The following is a description of a gene set: Genes up-regulated in gastric cancer cell lines resistant to 5-fluorouracil. studied in species Homo sapiens Human Gene Set: KANG_FLUOROURACIL_RESISTANCE_UP from publication Kang HC, Kim IJ, Park JH, Shin Y, Ku JL, Jung MS, Yoo BC, Kim HK, Park JG (PMID 14734480) PURPOSE: A major obstacle in chemotherapy is treatment failure due to anticancer drug resistance. The emergence of acquired resistance results from host factors and genetic or epigenetic changes in the cancer cells. The purpose of this study was to identify differentially expressed genes associated with acquisition of resistance in human gastric cancer cells. EXPERIMENTAL DESIGN: We performed global gene expression analysis in the acquired drug-resistant gastric cancer cell lines to the commonly used drugs 5-fluorouracil, doxorubicin, and cisplatin using Affymetrix HG-U133A microarray. The gene expression patterns of 10 chemoresistant gastric cancer cell lines were compared with those of four parent cell lines using fold-change and Wilcoxon's test for data analysis. RESULTS: We identified over genes differentially expressed in 5-fluorouracil-, cisplatin-, or doxorubicin-resistant gastric cancer cell lines. Our expression analysis also identified eight multidrug resistance candidate genes that were associated with resistance to two or more of the tested chemotherapeutic agents. Among these, midkine (MDK), a heparin-binding growth factor, was overexpressed in all drug-resistant cell lines, strongly suggesting that MDK might contribute to multidrug resistance in gastric cancer cells. CONCLUSIONS: Our investigation provides comprehensive gene information associated with acquired resistance to anticancer drugs in gastric cancer cells and a basis for additional functional studies., and this is the list of marker genes: CLU, CDKN1A, CCN3, KLC1, GPNMB, NQO1, LZTFL1, IGFBP2, CRY1, OSBPL3, TYMS, HOXB6, MDK, NR2F2, DGUOK, ARID5B, DDB2, LINC01278, SRI, SF3B3, BTG3, H3-3B